The following is a description of a gene set: Human Gene Set: GOBP_PTERIDINE_CONTAINING_COMPOUND_CATABOLIC_PROCESS The chemical reactions and pathways resulting in the breakdown of any compound containing pteridine (pyrazino(2,3-dipyrimidine)), e.g. pteroic acid, xanthopterin and folic acid. studied in species Homo sapiens, and this is the list of marker genes: ALDH1L2, AASDHPPT, MTHFS, PM20D2, ALDH1L1